The following is a description of a gene set: studied in species Mus musculus Mouse Gene Set: GOBP_POSITIVE_REGULATION_OF_CARDIAC_MUSCLE_CELL_DIFFERENTIATION Any process that activates or increases the frequency, rate or extent of cardiac muscle cell differentiation., and this is the list of marker genes: Tgfb1, Wnt3a, Gsk3b, Myocd, Kat2a, Mef2c, Bmp4, Efnb2, Nrg1, Arrb2